The following is a description of a gene set: The adhesion of one leukocyte to one or more other leukocytes via adhesion molecules. species: Mus musculus Mouse Gene Set: GOBP_LEUKOCYTE_AGGREGATION, and this is the list of marker genes: S100a8, Has2, Il1b, Rac2 (Rac family small GTPase 2), Gstp1, Cfh, Cd44, Jam2, Nr4a3, Stk10 (serine/threonine kinase 10), Adam8, S100a9, Cd47, Sema4d, Thbs1, Gm5849, Bmp7, Msn